The following is a description of a gene set: species: Homo sapiens Human Gene Set: GOBP_REGULATION_OF_PROTEIN_BINDING Any process that modulates the frequency, rate or extent of protein binding., and this is the list of marker genes: GREM2, DNAJB2, SYMPK, RAPGEF2, MAPK8 (mitogen-activated protein kinase 8), RACK1, IDE, USP9X (ubiquitin specific peptidase 9 X-linked), RPL11, IFIT2, DDX11, AKTIP, PEX14, TLE5, RALB, ITGA4, CFHR1, LDLRAP1 (low density lipoprotein receptor adaptor protein 1), BAX, TIAM1, IL10, XIRP1, SLPI, ADAM15, ADD2, FLOT1, BTBD1, NVL, TERT, STYX, CAMK1, NMD3, TRIM21, GNL3L, AURKA, MIR27B, PIN1, GAS8, ADIPOQ, GTF2F1, BDNF (brain derived neurotrophic factor), GOLGA2, PSME3IP1, MMP9, RAN, EPB41, ABL1, CARD18, CARD16, DACT1, GSK3B, CTNNBIP1, CSNK1E, PTPRF, USP33, DTX3L, MIR148A, ITGB1BP1, BAMBI, BMP4, CFHR2, NES, MITD1, ROCK1, EFHB, ADD1, LRPAP1, IFIT1, CFHR5, TMC8